Given this list of marker genes SLC25A51, SLC25A53 (NCBI Gene Id 401612), SLC25A52, SLC25A17, SLC25A47, here is a description of the gene set: Human Gene Set: GOBP_NAD_TRANSMEMBRANE_TRANSPORT The process in which a nicotinamide adenine dinucleotide is transported across a membrane; transport may be of either the oxidized form, NAD, or the reduced form, NADH. species: Homo sapiens